The following is a description of a gene set: Mouse Gene Set: GOBP_MITOCHONDRIAL_TRANSLATION species: Mus musculus The chemical reactions and pathways resulting in the formation of a protein in a mitochondrion. This is a ribosome-mediated process in which the information in messenger RNA (mRNA) is used to specify the sequence of amino acids in the protein; the mitochondrion has its own ribosomes and transfer RNAs, and uses a genetic code that differs from the nuclear code., and this is the list of marker genes: Mtif3, Taco1, Mrps9, Mrpl2, Mrpl49, Alkbh1, Mrps26, Trub2, Qrsl1, Mrps27, Mrps35, Chchd1, Mrpl44, Ptcd3, Rpusd3, Gfm1, Mrpl35, Mtg1, Mrpl47, Mrps30, Ears2 (glutamyl-tRNA synthetase 2, mitochondrial), Malsu1, Mrpl53, Mrpl12, Mtrf1, Mrpl16, Mrpl46, Mrps7, Mrpl41, Mrpl17 (mitochondrial ribosomal protein L17), Lrpprc, Mrpl14, Mrpl28, Mrpl22, Fastkd2, Mrps17, Mrpl9, Coa3, Mrpl43, Trmt10c, Gfm2, C1qbp, Mrpl42, Mettl8, Mrps14, Mrpl21, Mrps24, Mrps10, Mrpl40, Mrps11, Mrps21, Ngrn, Dap3, Mrps18a, Mrpl19, Mrpl20, Mrpl54, Mrpl3, Mrpl1, Mtg2, Gatb, Gadd45gip1, Mrps33, Mrpl57, Mrps31, Mrpl13, Mrpl51, Rmnd1, Mtif2, Mpv17l2, Lars2, Mrpl15, Mrps16, Mrps18c, Mrpl58, Ptcd1, Mrps25, Mrpl55, Rcc1l, Mrpl39, Mrpl27, Tsfm, Mrpl11, Mrpl37, Sars2, Nsun4, Mrpl52, Mrps5, Rpusd4, Mrpl24, Mrps2, Iars2, Mrps18b, Mrps28, Mrps34, Hars1 (histidyl-tRNA synthetase 1), Wars2, Mrpl23, Mrpl18, Mrps22, Mrpl34, Yars2, Mrps15, Dars2, Gatc, Mrpl30, Rars2 (NCBI Gene Id 76346), Nsun3, Mrpl32, Gars1, Mtrf1l, Mrpl48, Tufm, Mrpl50, Mrps12, Mrpl4, Mrps6, Uqcc2, Mrps23, Cdk5rap1, Fastkd3, Mrpl10, Shmt2, Mrpl36, Mrpl38, Aurkaip1, Mrpl33, Mrpl45, Aars2